Given this list of marker genes Kat6b, Cbx7, Ash2l, Dppa5a, Suv39h2, Dnmt3l, Zfp42, Nanog, Ccnb1, Cripto, Lin28a, here is a description of the gene set: Genes up-regulated in the induced pluripotent cells (iPS) and embryonic stem cells (ES) compared to the parental lineage-committed and partially reprogrammed cell lines. studied in species Mus musculus Somatic cells can be reprogrammed to a pluripotent state through the ectopic expression of defined transcription factors. Understanding the mechanism and kinetics of this transformation may shed light on the nature of developmental potency and suggest strategies with improved efficiency or safety. Here we report an integrative genomic analysis of reprogramming of mouse fibroblasts and B lymphocytes. Lineage-committed cells show a complex response to the ectopic expression involving induction of genes downstream of individual reprogramming factors. Fully reprogrammed cells show gene expression and epigenetic states that are highly similar to embryonic stem cells. In contrast, stable partially reprogrammed cell lines show reactivation of a distinctive subset of stem-cell-related genes, incomplete repression of lineage-specifying transcription factors, and DNA hypermethylation at pluripotency-related loci. These observations suggest that some cells may become trapped in partially reprogrammed states owing to incomplete repression of transcription factors, and that DNA de-methylation is an inefficient step in the transition to pluripotency. We demonstrate that RNA inhibition of transcription factors can facilitate reprogramming, and that treatment with DNA methyltransferase inhibitors can improve the overall efficiency of the reprogramming process. Mouse Gene Set: MIKKELSEN_PLURIPOTENT_STATE_UP from publication Mikkelsen TS, Hanna J, Zhang X, Ku M, Wernig M, Schorderet P, Bernstein BE, Jaenisch R, Lander ES, Meissner A (PMID 18509334)